Given this list of marker genes Bmi1, Ehmt1, Tfdp1 (transcription factor Dp 1), Pcgf2, E2f6, Pcgf6, Max, Ring1, L3mbtl2, Rbbp4, Yaf2 (NCBI Gene Id 67057), Phc1 (NCBI Gene Id 13619), Ezh2, Rbbp7, here is a description of the gene set: This event has been computationally inferred from an event that has been demonstrated in another species.<p>The inference is based on the homology mapping from PANTHER. Briefly, reactions for which all involved PhysicalEntities (in input, output and catalyst) have a mapped orthologue/paralogue (for complexes at least 75% of components must have a mapping) are inferred to the other species. part of: Generic Transcription Pathway studied in species Mus musculus electronically inferred by orthology from the curated human pathway Reactome Pathway: Transcriptional Regulation by E2F6